Given this list of marker genes CAV1, ABCA8, ADAMTS8, RASL12, AGER, ADAMTSL3, PHACTR2, NR2F2, SSC4D, PGM5, VWF, MCL1, ADARB1, here is a description of the gene set: Down-regulated genes characteristic to the squamous cell carcinoma (SCC) type of non-small cell lung cancer (NSCLC). from publication Inamura K, Fujiwara T, Hoshida Y, Isagawa T, Jones MH, Virtanen C, Shimane M, Satoh Y, Okumura S, Nakagawa K, Tsuchiya E, Ishikawa S, Aburatani H, Nomura H, Ishikawa Y (PMID 16007138) Human Gene Set: INAMURA_LUNG_CANCER_SCC_DN studied in species Homo sapiens Current clinical and histopathological criteria used to define lung squamous cell carcinomas (SCCs) are insufficient to predict clinical outcome. To make a clinically useful classification by gene expression profiling, we used a 40 386 element cDNA microarray to analyse 48 SCC, nine adenocarcinoma, and 30 normal lung samples. Initial analysis by hierarchical clustering (HC) allowed division of SCCs into two distinct subclasses. An additional independent round of HC induced a similar partition and consensus clustering with the non-negative matrix factorization approach indicated the robustness of this classification. Kaplan-Meier analysis with the log-rank test pointed to a nonsignificant difference in survival (P = 0.071), but the likelihood of survival to 6 years was significantly different between the two groups (40.5 vs 81.8%, P = 0.014, Z-test). Biological process categories characteristic for each subclass were identified statistically and upregulation of cell-proliferation-related genes was evident in the subclass with poor prognosis. In the subclass with better survival, genes involved in differentiated intracellular functions, such as the MAPKKK cascade, ceramide metabolism, or regulation of transcription, were upregulated. This work represents an important step toward the identification of clinically useful classification for lung SCC.